Given this list of marker genes Htt, Gsto1, Jph2, Fgf14, Atp2a1, Ank2, Slc9a1, Casq1, Strit1, Stim1, Hspa2, Nipsnap2, Ehd3, Pkd2 (polycystin 2, transient receptor potential cation channel), Calm3, Stim2, Stac3, Hap1, Vmp1, Stimate, Asph, Calm2, Cacnb2, Cacnb3, Sumo1, Gstm7, Calm1, Stac2 (NCBI Gene Id 217154), Stac, Cracr2a, Plcg2, here is a description of the gene set: Any process that activates or increases the frequency, rate or extent of calcium ion transmembrane transporter activity. studied in species Mus musculus Mouse Gene Set: GOBP_POSITIVE_REGULATION_OF_CALCIUM_ION_TRANSMEMBRANE_TRANSPORTER_ACTIVITY